The following is a description of a gene set: studied in species Mus musculus part of: Rab regulation of trafficking Reactome Pathway: TBC/RABGAPs electronically inferred by orthology from the curated human pathway This event has been computationally inferred from an event that has been demonstrated in another species.<p>The inference is based on the homology mapping from PANTHER. Briefly, reactions for which all involved PhysicalEntities (in input, output and catalyst) have a mapped orthologue/paralogue (for complexes at least 75% of components must have a mapping) are inferred to the other species., and this is the list of marker genes: Rab35, Tbc1d24, Optn, Rab33a, Rab4a, Tbc1d15 (TBC1 domain family, member 15), Rab6a, Rab8a, Gabarap, Arf6, Map1lc3b, Rab8b, Rabgap1, Tbc1d7, Ulk1, Tbc1d2, Tbc1d10a, Rab7, Tbc1d17, Gabarapl2, Tbc1d13, Rab11a, Tsc1